Given this list of marker genes Pla2g3, Etnppl, Pla2g12a, Pla2g4e, Mboat1, Agpat3, Miga1, Hadha, Dgat2l6, Csnk2a2, Pla2g4b, Lpgat1, Slc44a2, Mboat2 (membrane bound O-acyltransferase domain containing 2), Cept1, Pnpla2, Pla2g10, Pla2g4a, Lpcat4 (lysophosphatidylcholine acyltransferase 4), Tmem86b, Abhd4, Gpam, Gpd1, Pcyt1a, Lpcat2, Osbpl5, Pemt, Mfsd2a, Pnpla8, Pcyt2, Chpt1, Cpne1, Alpi, Pla1a, Plaat3, Cdipt, Lpin2, Pla2g4f, Pgp, Plaat1, Pld6, Slc44a1, Pla2g2f, Ddhd2, Dgat2, Pla2r1, Lpcat3, Chka, Csnk2b, Etnk2, Agpat2, Pla2g1b (NCBI Gene Id 18778), Osbpl8, Pitpnm1 (NCBI Gene Id 98172), Mboat7, Stard7, Hadhb, Osbpl10, Pitpnm3, Ptdss2, Pla2g4c, Chat, Liph, Phospho1, Mgll (NCBI Gene Id 57888), Pla2g2d, Cpne3, Pla2g5, Agk, Pla2g15, Slc44a4, Pitpnm2, Ddhd1 (NCBI Gene Id 97927), Plb1, Abhd3, Ptdss1, Cpne7, Awat2, Lpin3, Gpat3, Selenoi, Gpat2, Gpd1l, Plbd1, Agpat1, Lipi, Miga2, Pnpla3, Pla2g2e, Stard10, Lpcat1, Cds2, Gpd2, Pcyt1b, Pla2g2a, Tafazzin, Pla2g6, Slc44a3, Cds1, Csnk2a1, Dgat1, Chkb, Slc44a5, Lclat1, Gpat4, Crls1, Agpat4 (1-acylglycerol-3-phosphate O-acyltransferase 4), Acp6 (acid phosphatase 6, lysophosphatidic), Gnpat, Pctp, Pla2g4d, Agpat5, Plaat5, Etnk1, Pitpnb, Cpne6, Pld2, here is a description of the gene set: Mouse Gene Set: REACTOME_GLYCEROPHOSPHOLIPID_BIOSYNTHESIS Glycerophospholipid biosynthesis studied in species Mus musculus